The following is a description of a gene set: Abnormal odontoid tissue morphology studied in species Homo sapiens An abnormality of an odontoid tissue. Human Gene Set: HP_ABNORMAL_ODONTOID_TISSUE_MORPHOLOGY, and this is the list of marker genes: RNF113A, MMP20, TNFRSF11A, COMT, KCNJ2, FGF10, NCF1, DLX3, COL7A1, KLK4, EDARADD, TMEM165, HCCS, ERCC1, FAM83H, CRTAP, CIB2 (NCBI Gene Id 404086), TARS1, SMARCA2, BMP1, RNU12, IL17F, RREB1, GNAS, IFITM5, DNAJC21, EP300, CHD3, COG6 (component of oligomeric golgi complex 6), AMELX (NCBI Gene Id 265), CTSK, RELT, USH2A, OCRL, PEX6, LRP6, SEC24D, STX1A, CARS1, TBX1, VDR, CCDC8, LRP4, ERCC3, SATB1, TSC2, MBTPS2, LAMA3, PLEC, WDR19, PIK3C2A, EDA, DSPP (dentin sialophosphoprotein), APC (APC regulator of WNT signaling pathway), BUD23, FKBP6, SEC24C, TP63, PDZD7, TMEM38B, PHEX, TBL2 (NCBI Gene Id 27203), DHCR7, STIM1, GP1BB, WHRN, TMEM270, GTF2I, EIF4H (NCBI Gene Id 94573), ERCC2, ENAM, COL1A2, NDUFB11, CLDN19, ITGB4, WDR35, RAD21, ZNF469, PCNT, GTF2E2, IKBKG, PIK3R1, RUNX2, SERPINH1, CLDN16, TCIRG1, CENPE, GJA1, STAT3, MMP1, SLC10A7, AKT1, COL17A1, TRAIP, B3GALT6, TSC1, IFT43, FKBP10, VPS37D, IL17RA, GTF2IRD2 (GTF2I repeat domain containing 2), POLR1C, JMJD1C, ODAPH, AIRE, CREBBP, IRF6, LAMC2 (laminin subunit gamma 2), OFD1, SPARC, ATR, SCUBE3, KRT14, NECTIN1, OBSL1, SLC13A5, FGFR3, ESPN, CDH23, LIMK1, USH1G, GALNT3, PAK2, GPR68, SUMO1, NF1, ANAPC1, AMTN, DDX59 (NCBI Gene Id 83479), NUP85, MYO7A, CLDN1, ITGA6, PGAP1 (NCBI Gene Id 80055), IL17RC, POLR1B, ADGRV1, RBBP8, HRAS, MIA3, NECTIN4, GRHL2, ATRIP, HLA-DQA1, GLB1 (galactosidase beta 1), AXIN2, ALDH3A2, CEP152, PORCN, PDE4D, ROGDI, SLC24A4, STX16, BMP4, TTC7A, PEX1, FAM20A, HIRA, UFD1, SLC35A2, HLA-DQB1, CUL7, GTF2H5, CYP27B1, GALNS, CCDC134, P4HB, ELMO2, DNAJC30, COX7B, WDR72, MPLKIP, TRIP11, PPIB, SP7, KRT5, CLIP2, ERCC8, CLEC7A, ELN, ORAI1, SP6, PTDSS1, IFNG, LTBP3, FERMT1, AMBN, PCDH15, MSX1, CNNM4, USH1C, GTF2IRD1, TRAF3IP2, TRIM37, RFC2, BAZ1B, TGFA, PLK4, POLR1D, SLC29A3, WNT10A, IFT52, ERCC6, FAM20C, IFT122, FGFR2, P3H1, FGF3, LONP1, ARVCF, SMARCD2, CYP2R1, TBCE, FBXO28, DIAPH1, TCOF1, IRX5, AARS1, METTL27, ACP4, LMX1B, FLNB, WNT10B, FOSL2, FGFR1, COL1A1, SMOC2, ITGB6, SERPINF1, POLD3, GNB2 (G protein subunit beta 2), NUP133, CTBP1, DNA2, RECQL4 (NCBI Gene Id 9401), LAMB3 (NCBI Gene Id 3914), ERCC4 (ERCC excision repair 4, endonuclease catalytic subunit), RHOA, PAX9